Given this list of marker genes HDGFL3, RPL37, TRHDE, AASS, APOL5, DNAAF11, ZNF770, PDE7A, ZNF474, DNAJA1, PDS5B, ROBO2, CLEC6A, MACIR, DUSP8, MMP13, HPS3 (HPS3 biogenesis of lysosomal organelles complex 2 subunit 1), NEK2, UBE2Q2, ZNF561, CYB5D1, GCM2, LGSN, CDK16, GOSR2, PUM2, INSIG1, TENT5A, SGCE, RC3H1, LDHA (NCBI Gene Id 3939), ARHGEF7, ACACA, DNAJC12, MRPS35, PTPN4, NFAT5, SLC26A7, CALML4, PPP1CB, ZIC4, BRF2, IFNA10, IRS2, UBE2W, KMT5B, IPMK, ACSL6, CRISP2, HADHB, MARCHF1 (NCBI Gene Id 55016), ATP11C, BZW1, FOXD2, SLMAP, ZMYM5, CD55, ST18, UGT2B10, TMEM231 (transmembrane protein 231), INTS6, ZNF230, TRPM6, OGG1, AKR1E2, PTPRK, ABCA1, APPL1, DGKB, DISC1, UGT2B28, CORO1C, PMP22, PRKG1, UGT8, PDPK1 (NCBI Gene Id 5170), IFNA17 (NCBI Gene Id 3451), INO80D, RASL11B, SRRM1, GPX8, ADD1, GCNA, KCNC2, TMEM47, NDUFB4, TGS1, CLUAP1, CHML (NCBI Gene Id 1122), ENDOU, TMEM87A, CCND2, HINT1 (NCBI Gene Id 3094), AUTS2, LILRB5, UGT2B7 (UDP glucuronosyltransferase family 2 member B7), MLKL, GDPD1, GABRR1, HEPHL1, here is a description of the gene set: Genes predicted to be targets of miRBase v22 microRNA hsa-miR-4317 in miRDB v6.0 with MirTarget v4 prediction scores > 80 (high confidence targets). from publication Chen Y, Wang X (PMID 31504780) species: Homo sapiens Human Gene Set: MIR4317